The following is a description of a gene set: Pathway Definition from KEGG: IFN -> IFNR -> JAKs -> STAT+IRF9 => (RIPK1+RIPK3) IFN-RIPK1/3 signaling pathway. Pathway ID: N01662. Pathway type: Reference. Pathway class: nt06527 Necroptosis. Human Gene Set: KEGG_MEDICUS_REFERENCE_IFN_RIPK1_3_SIGNALING_PATHWAY species: Homo sapiens, and this is the list of marker genes: IFNGR2, IFNGR1, JAK2, IFNA14, IFNA4, JAK3, TYK2, IFNA5, IFNA21, STAT5A (NCBI Gene Id 6776), IFNA1, RIPK3, STAT3, IFNA13, IFNA6 (interferon alpha 6), IFNAR1, JAK1, IFNG, IFNA10, STAT1, IFNA8, RIPK1, STAT4, STAT6, IFNA17, IFNA7, IFNAR2, STAT2, IFNA16, IRF9, IFNA2